The following is a description of a gene set: Human Gene Set: HOFT_CD4_POSITIVE_ALPHA_BETA_MEMORY_T_CELL_BCG_VACCINE_AGE_18_45YO_56D_TOP_100_DEG_AFTER_IN_VITRO_RE_STIMULATION_DN species: Homo sapiens Protective efficacy of Bacillus Calmette-Guerin (BCG) may be affected by the methods and routes of vaccine administration. We have studied the safety and immunogenicity of oral (PO) and/or intradermal (ID) administration of BCG in healthy human subjects. No major safety concerns were detected in the 68 healthy adults vaccinated with PO and/or ID BCG. Although both PO and ID BCG could induce systemic Th1 responses capable of IFN-gamma production, ID BCG more strongly induced systemic Th1 responses. In contrast, stronger mucosal responses (TB-specific secretory IgA and bronchoalveolar lavage T cells) were induced by PO BCG vaccination. To generate preliminary data comparing the early gene signatures induced by mucosal and systemic BCG vaccination, CD4<sup>+</sup> memory T cells were isolated from subsets of BCG vaccinated subjects pre- (Day 0) and post-vaccination (Days 7 and 56), rested or stimulated with BCG infected dendritic cells, and then studied by Illumina BeadArray transcriptomal analysis. Notably, distinct gene expression profiles were identified both on Day 7 and Day 56 comparing the PO and ID BCG vaccinated groups by GSEA analysis. Future correlation analyses between specific gene expression patterns and distinct mucosal and systemic immune responses induced will be highly informative for TB vaccine development. Genes down-regulated in CD4-positive, alpha-beta memory T cell 56d vs 0d in adults (18-45) after exposure to BCG vaccine, time point 56D, administered PO (oral). Comment: top 100 most differentially expressed genes comparing Day 0 and Day 56 responses after in vitro re-stimulation with BCG-infected autologous dendritic cells from publication Hoft DF, Xia M, Zhang GL, Blazevic A, Tennant J, Kaplan C, Matuschak G, Dube TJ, Hill H, Schlesinger LS, Andersen PL, Brusic V (PMID 28853442), and this is the list of marker genes: RUBCNL, ERC1, AP2A1, NOC2L, NFATC3, CXCR5, TRAF7, TLE3, THBS1, ABCC1, CREG1, MGAT4B, KIF11, CNOT3, ZNF184, PLXNA1, SLC29A1, IFIT1, CXCL1, ARHGAP17, GBF1, VCAN, HDAC7, TMEM94, WASF2, MFSD12, MFHAS1, INTS5, ZNF763, RPRD2 (NCBI Gene Id 23248), OASL, HDGFL3, JUP, BMP2K, ARMC6, EIF3B, TAF1, PYGO2, ARAP1, ARHGEF11, MYO1C, PTGIR, IRF2BP1, ADCY1, TRANK1, SAMD4B, IFIT3